The following is a description of a gene set: Mouse Gene Set: GOBP_LEPTIN_MEDIATED_SIGNALING_PATHWAY The series of molecular signals initiated by leptin binding to its receptor on the surface of a cell, and ending with the regulation of a downstream cellular process, e.g. transcription. Leptin is a hormone manufactured primarily in the adipocytes of white adipose tissue, and the level of circulating leptin is directly proportional to the total amount of fat in the body. species: Mus musculus, and this is the list of marker genes: Bbs4, Lepr, Lep, Ugcg, Acbd7, Prmt2, Mkks, Sirt1, Mt3, Stat3, Bbs2, Adipor1